The following is a description of a gene set: Tumors arising in BRCA1 and BRCA2 mutation carriers appear to have specific pathological and gene expression profiles, which show a high level of concordance. BRCA1 tumors are high-grade, negative for hormone receptors, have a high proliferation rate, and are positive for some cell cycle promoter genes. BRCA2 tumors present a phenotype opposite to BRCA1 tumors but very similar to sporadic tumors, except that BRCA2 overexpress some DNA repair markers such as CHEK2, show high cytoplasmic expression of RAD51, and are negative for HER-2 amplification and expression. Some of these characteristics have also been found in cDNA expression studies, although more analysis are necessary in order to obtain new markers that can be associated with a germ line mutation in BRCA1 or BRCA2. In this way, some studies in normal tissues of BRCA1/2 carriers suggest that differences exist in the level of expression of some genes when compared with noncarriers. Finally, IHC studies in tumors carrying a mutation in CHEK2 are rare and show contradictory results, probably due to the low number of these cases. However, they represent an example showing how different mutations of the same gene may be associated with specific histological subtypes of cancer. studied in species Homo sapiens from publication Honrado E, Osorio A, Palacios J, Benitez J (PMID 16998498) Genes distinguishing between breast cancer tumors bearing mutations in BRCA1 and those with mutated BRCA2. Human Gene Set: HONRADO_BREAST_CANCER_BRCA1_VS_BRCA2, and this is the list of marker genes: CCNB1, SKP2, PGR, TOP2A, KRT8, IFI27, RAD50, CCNA2, MDM2, EREG, CCNE1, EGFR, MKI67, CCND1, BCL2, BIRC5, VIM